Given this list of marker genes Commd6, Hspa1a, Cdk5rap3, Akap8, Pdcd11, Hif1an, Gsk3b, Faf1, Setd6, Notch2, Ppard, Taf4b, Apex1, Rnf25, Ep300, Nfkbid, Ankrd42, Hdac1, Hdac2, Hspa1b, Cdkn2a, Dnaja3, Bcl10, Nfkbia, Brms1, Cpne1, Hdac3, Commd7, Trp53bp2, Commd8, Anxa4, Npm1, Psma6, Rela, Mtdh, here is a description of the gene set: Mouse Gene Set: GOMF_NF_KAPPAB_BINDING Binding to NF-kappaB, a transcription factor for eukaryotic RNA polymerase II promoters. studied in species Mus musculus